The following is a description of a gene set: Abnormal pigmentation of the iris. Abnormal iris pigmentation Human Gene Set: HP_ABNORMAL_IRIS_PIGMENTATION studied in species Homo sapiens, and this is the list of marker genes: RASA2, HRAS, UBE4B, RRAS2, HPS6, MAGEL2, PITX2, KITLG, PEX11B, PEX10, USH1G, PDZD7, MITF, ADGRV1, ACTG1, IMPG2, PEX1, USH2A, CBL, BLOC1S6, PAH, MT-TS2, SOS2, KIT, LIMK1, PEX14, LZTR1, PEX26, PRDM16, ATP10A, NDN, PNPLA6, LUZP1, IMPG1, WHRN, TYR, PAX3, SOX10, SLC45A2, KRAS, LYST, PCDH15, PEX6, MYO7A, BAZ1B, GPR143, CLIP2, MAFB, KANSL1 (KAT8 regulatory NSL complex subunit 1), EPG5, PEX13, TMEM270, MYH11, VPS37D, LRMDA (NCBI Gene Id 83938), METTL27, PTPN11 (protein tyrosine phosphatase non-receptor type 11), AP3B1, RAF1, PRR12, COL18A1, PRKCZ, MLXIPL, PDE4D, EDC3, PEX12, PRPH2, CIB2, BLOC1S3, DNAJC30, SKI, MAPK1, STX1A, USH1C, GTF2IRD2, C1QTNF5, DTNBP1, PEX2, TP63, GABRD, PDPN, RIT1, MYO5A, MRAS, CHRDL1, GNAQ, CDH23, RFC2, MMP23B, CLRN1, SOS1 (NCBI Gene Id 7838), TBL2, UBE3A, XYLT2, PTEN, PEX16, PEX3, BEST1, RLIM, SPEN, EDNRB, HARS1, MC1R, BLOC1S5, ESPN, ELP1, EDN3, LMX1B, GTF2IRD1, SNRPN, OCA2, TYRP1, HPS5 (NCBI Gene Id 246309), KCNAB2, WDR45, AKT1, SALL4, HPS4 (HPS4 biogenesis of lysosomal organelles complex 3 subunit 2), ELN, CEP78, EIF4H, RRAS, AP3D1, CHN1, RERE, SNAI2, FKBP6, BUD23, SPRED2, RAB27A, NCF1, ARSG, HERC2, MLPH (melanophilin), HSPG2, DCT, PEX5, GTF2I, PEX19 (peroxisomal biogenesis factor 19), SLC24A5, ADAMTSL4, PRKAR1A, NRAS, CPAMD8, HPS1, CASZ1, ACTB